The following is a description of a gene set: species: Homo sapiens Human Gene Set: GOMF_SMAD_BINDING Binding to a SMAD signaling protein., and this is the list of marker genes: COL3A1, EID2, ZBTB7A, PARP1, AXIN1, TGFB1I1, GATA4, TGIF1, TGFBR2, MEF2A, STUB1, SMAD9, SMAD7, FKBP1A (FKBP prolyl isomerase 1A), PURA, JUN, ANKRD1, PMEPA1, DAB2, MEN1, COL5A2, BMPR1A, PML (NCBI Gene Id 5371), TGFBRAP1, SMAD6, SMAD4, BMPR1B, SMURF1, CITED2, SMAD5, ACVRL1, HMGA2 (high mobility group AT-hook 2), RANBP3L, FERMT2, COL1A2, SMAD2, ZC3H3, FLNA, HIPK2, PPM1A, ACVR1B, TGFBR1, SKOR2, SKOR1, AXIN2 (NCBI Gene Id 8313), USP9X, SMAD1, RNF111, ZEB2, PPARG, DDX5, IPO7, TOB1, SKI, DROSHA, RGCC, TGFBR3, SNW1, CTNNB1, CREB3L1, ACVR1, FOS, MYOCD, SMAD3, RANBP3, MAGI2, CITED1, PURB, ZMIZ1, SMURF2 (NCBI Gene Id 64750), TCF12, FOXH1, MTMR4, YY1, LDLRAD4 (NCBI Gene Id 753), PAX6, SKIL, USP15, TRIM33, USP9Y